Given this list of marker genes TRPV4, GNAQ, KDR, GNG8, GNG11, CTNNB1, ADCY3, GNA11, GNG2, PRKACG, GNB5, ADCY2, GNB4, RAMP2, GNG7, MLST8, RICTOR, CAPNS1, MAPKAP1 (MAPK associated protein 1), CDH5, GNGT2, PIK3CA, CAPN2, PANX1, PRR5, GNB3, PIK3CD, FYN, ADM, CAPNS2, ADCY9, GNG13, P2RY2, GNG5, PRKAR2B, ADCY1, GNGT1, GNG10, GNAS, PRKACB, PRKAR2A, GNB2, PKN2, ADCY4, PRKAR1B, CALM1 (NCBI Gene Id 801), CALCRL, ADCY7, GNG12, ADCY5, GNG3, PRKACA (protein kinase cAMP-activated catalytic subunit alpha), NOS3, AKT1, PIEZO1, PECAM1, PIK3CB, MTOR, GNB1, FLT4, MMP14 (NCBI Gene Id 4323), TLN1, GNG4, PIK3R2, VCL, PDPK1, ADCY8, PRKAR1A, ADCY6, here is a description of the gene set: High laminar flow shear stress activates signaling by PIEZO1 and PECAM1:CDH5:KDR in endothelial cells Human Gene Set: REACTOME_HIGH_LAMINAR_FLOW_SHEAR_STRESS_ACTIVATES_SIGNALING_BY_PIEZO1_AND_PECAM1_CDH5_KDR_IN_ENDOTHELIAL_CELLS species: Homo sapiens